Given this list of marker genes Wnt7b, Umod, Pkd1, Pkd2, Aqp1, Pou3f3, here is a description of the gene set: The process whose specific outcome is the progression of the metanephric loop of Henle over time, from its formation to the mature structure. The metanephric loop of Henle is a metanephric nephron tubule that connects the proximal convoluted tubule to the distal convoluted tubule in the metanephros. studied in species Mus musculus Mouse Gene Set: GOBP_METANEPHRIC_LOOP_OF_HENLE_DEVELOPMENT